The following is a description of a gene set: The structural rearrangement of collagen fibres in hypertrophic scar causes abnormal contracture, low tensile strength, and raised scars, which cause functional impairment and disfigurement. It is hypothesized that changes in the genes of cytokines, extracellular matrix proteins, and proteins regulating programmed cell death are related to hypertrophic scar formation. To test this hypothesis, fibroblasts were cultured from hypertrophic scars and their response to interleukin-6 (IL-6) stimulation was studied by defining their gene expression profiles. Affymetrix gene chip analysis was used to identify up- or down-regulation in the genes present in the affymetrix array. RT-PCR and ELISA assays were used to validate microarray expression profiles further. Comparison of gene profiles showed an increase of genes in hypertrophic scar fibroblasts compared with normal skin fibroblasts, while the expression of genes decreased. Thirty-three genes were affected by IL-6 treatment in the hypertrophic scar fibroblasts, while genes were affected in normal skin fibroblasts. Messenger RNA to beta-actin ratios for matrix metalloproteinase-1 (MMP-1) and MMP-3 were increased with IL-6 in normal skin fibroblasts from 2.43 +/- 0.06 to 5.50 +/- 0.45 and from 0.75 +/- 0.09 to 1.98 +/- 0.01, respectively. No change in these matrix metalloproteinases could be shown with IL-6 stimulation in hypertrophic scar fibroblasts. Secreted protein levels of pro-MMP-1 and MMP-3 were elevated in the supernatants from normal skin fibroblasts from 2.00 +/- 0.09 and 1.72 +/- 0.10 ng/ml to 4.60 +/- 0.12 and 3.41 +/- 0.20 ng/ml, respectively, after treatment with IL-6 (p < 0.05). No changes were observed in hypertrophic scar fibroblasts treated with IL-6. Values are means +/- SEM. The absence of any up-regulation of MMP-1 and MMP-3 in hypertrophic scar fibroblasts, in response to IL-6, suggests that suppression of matrix metalloproteinases may play a role in the excessive accumulation of collagen formed in hypertrophic scars. While the pathogenesis of abnormal hypertrophic scars remains poorly understood, the use of gene expression arrays may prove helpful in identifying the mechanisms responsible for this type of abnormal scar formation and in formulating an effective therapeutic protocol. Human Gene Set: DASU_IL6_SIGNALING_SCAR_DN species: Homo sapiens Genes down-regulated in hypertrophic scar fibroblasts in response to IL6. from publication Dasu MR, Hawkins HK, Barrow RE, Xue H, Herndon DN (PMID 15095275), and this is the list of marker genes: SULF1, TPM1, LOXL2, PDGFRA, SGK1, THBS1, PSG6, SERPINE1, TMBIM6, CCN2, PPP1R3C, PRPS1, ADAM10, ID3, HMOX1, CCN1